The following is a description of a gene set: Marker genes curated from the annotated cluster as represented in the Descartes Human Gene Expression During Development database. The gene expression program underlying the specification of human cell types is of fundamental interest. The study authors generated human cell atlases of gene expression and chromatin accessibility in fetal tissues. For gene expression, the study authors applied three-level combinatorial indexing to >110 samples representing 15 organs, ultimately profiling ~4 million single cells. The study authors leveraged the literature and other atlases to identify and annotate hundreds of cell types and subtypes, both within and across tissues. Our analyses focused on organ-specific specializations of broadly distributed cell types (such as blood, endothelial, and epithelial), sites of fetal erythropoiesis (which notably included the adrenal gland), and integration with mouse developmental atlases (such as conserved specification of blood cells). These data represent a rich resource for the exploration of in vivo human gene expression in diverse tissues and cell types. studied in species Homo sapiens Human Gene Set: DESCARTES_MAIN_FETAL_PDE11A_FAM19A2_POSITIVE_CELLS from publication Cao J, O'Day DR, Pliner HA, Kingsley PD, Deng M, Daza RM, Zager MA, Aldinger KA, Blecher-Gonen R, Zhang F, Spielmann M, Palis J, Doherty D, Steemers FJ, Glass IA, Trapnell C, Shendure J (PMID 33184181), and this is the list of marker genes: C7orf25, SCN8A, KLHL14, CACNB4, SNORA58, OSBPL9P4, SH3BP4, SEMA3A, NRG3-AS1, PCDH7, SLIT2 (NCBI Gene Id 9353), KCNB2, DIRAS2, MEGF10 (multiple EGF like domains 10), RELN, CABP1, IQSEC3, RNU7-187P, FEZF1-AS1, HMGB1P49, ERCC6, GABRD, PCLO, GABRA2, LINC02259, HSPD1P13, ARHGEF7-IT1, RNU6-890P, MIR218-1, RASGEF1B, TAGLN3, SNAP25, ANKRD20A8P (ankyrin repeat domain 20 family member A8, pseudogene), ANKRD20A7P, FILIP1L, NPM1P41, SLIT2-IT1, RNU6-457P, NSG2, RNU6-8 (NCBI Gene Id 101954278), LINC01501, GRIN2A, FAM88B, RBFOX1 (RNA binding fox-1 homolog 1), KCNAB1, PCDH9-AS2, PDE11A, RNU7-99P, ANKRD20A4P, FANCD2P2, LINC01414, FRMD7, CNMD, HLF, PPFIA2, ENSG00000262999, RN7SL68P, TMPRSS11GP, CCDC88A, SLC26A5-AS1, NEGR1-IT1, ENSG00000248479, PCDH9-AS1, POU6F2, CHAT, PCDH9, KRT17P1, PCDHA10, CSGALNACT2-DT, RNU6-4P, ADAMTS18, AACSP1 (acetoacetyl-CoA synthetase pseudogene 1), API5P2, PAK3, ANKRD28, DAAM1, GALNT15